The following is a description of a gene set: Human Gene Set: HP_COMA studied in species Homo sapiens Coma The complete absence of wakefulness and consciousness, which is evident through a lack of response to any form of external stimuli., and this is the list of marker genes: PRF1, PRRT2, BRAF, GLUD1, POLR3K, TXNRD2, INSR, TTC19, HLCS, HADH, TLR3, UNC93B1, HNF4A, ACAT1, ASS1, KCNJ11 (NCBI Gene Id 3767), CFH, ATP1A2, NDUFA2, STAR, CPT1A, HMGCS2, FBP1, NFKB2, SLC19A3, ACADM (acyl-CoA dehydrogenase medium chain), SLC7A7, NDUFS4, MMAB, ETFA, EIF2B5, ASL, CPT2, GCK, CFHR3, BCKDHA, GK, RANBP2, CACNA1A, STXBP2, MMUT, PPOX, MRAP, TBK1, NAGS, AUH, IVD, ETFDH, MCCC1, STAT3, SOX10, MC2R, SCN1A (NCBI Gene Id 6323), CFHR1, SLC25A13, HNF1A, SQOR, ETFB, UCP2, CPS1, LYRM7, SLC22A5, INS, CDKN2C, APP, ABCC8, CTNNB1, CDKN1A, ALDOB, POLG, IL18BP, HADHB, PCCB, HMBS, MMAA, HADHA, TRAF3, ATP7B, TANGO2, MCCC2, STX11, PDX1, OTC, KYNU, PCCA, CYC1, CDKN2B, MEN1, TICAM1 (TIR domain containing adaptor molecule 1), NNT, CDKN1B, NAXE, SLC25A20, SLC25A15, AKT2, GCSH, YY1, HMGCL, UNC13D